The following is a description of a gene set: An thiol-dependent isopeptidase activity that cleaves ubiquitin from a target protein to which it is conjugated. Mouse Gene Set: GOMF_CYSTEINE_TYPE_DEUBIQUITINASE_ACTIVITY studied in species Mus musculus, and this is the list of marker genes: Usp17la, Otud1, Otud6b, Usp49, Uchl4, Usp39, Usp26, Alg13, Otud7b, Otud6a, Josd2, Otud3, Usp7, Usp9y, Otud4, Usp33, Mindy3 (MINDY lysine 48 deubiquitinase 3), Usp22 (ubiquitin specific peptidase 22), Usp53, Usp51, Josd1, Usp27x, Usp30, Usp17lb, Usp1, Usp28 (ubiquitin specific peptidase 28), Usp47, Usp17ld, Eif3f, Usp8, Otulin, Brcc3 (NCBI Gene Id 210766), Usp48, Usp34, Usp17le, Usp40, Usp38, Yod1, Otud5, Usp25, Usp21, Usp14, Usp45 (ubiquitin specific petidase 45), Uchl3, Usp54, Mindy1, Usp42, Usp37, Otud7a, Usp16 (NCBI Gene Id 76164), Usp29, Senp3, Usp18, Usp35, Usp17lc, Usp43, Usp31, Otub1, Usp3, Uchl5, Usp19 (ubiquitin specific peptidase 19), Uchl1, Usp32, Zranb1, Usp9x, Usp2, Mindy2, Usp4, Usp11 (ubiquitin specific peptidase 11), Usp12, Usp5, Otub2, Tnfaip3, Bap1, Usp24, Cyld, Zc3h12a, Brcc3dc, Usp13 (ubiquitin specific peptidase 13 (isopeptidase T-3)), Atxn3, Usp15, Usp36, Vcpip1, Usp46, Tank, Usp44, Usp10, Mindy4, Usp20, Desi2, Zup1, Usp50